The following is a description of a gene set: from publication Chen Y, Wang X (PMID 31504780) Genes predicted to be targets of miRBase v22 microRNA mmu_miR_6420 in miRDB v6.0 with MirTarget v4 prediction scores > 80 (high confidence targets). studied in species Mus musculus Mouse Gene Set: MIR_6420, and this is the list of marker genes: Slc2a2, Pglyrp4, Acsl3, Tigd2, Rab39b, Dcaf17 (NCBI Gene Id 98971), Lrp2, Rnps1, Arhgap32, Cd226, Clec4d, Dennd4a, Egf, Arhgap42, Nup153, Cfap300, Zfp106, Syncrip, Bfsp1, Ptgdr2, Dusp8, Camk2d